The following is a description of a gene set: species: Mus musculus Mouse Gene Set: GOMF_HISTONE_H3K27_METHYLTRANSFERASE_ACTIVITY Catalysis of the reaction: S-adenosyl-L-methionine + histone H3 L-lysine (position 27) = S-adenosyl-L-homocysteine + histone H3 N6-methyl-L-lysine (position 27). This reaction is the addition of a methyl group to the lysine residue at position 27 of the histone H3 protein., and this is the list of marker genes: Ezh2, Ehmt1 (euchromatic histone methyltransferase 1), Ehmt2, Jarid2, Ezh1, Nsd3